Given this list of marker genes Deptor, Rtn2, Akr1b10, Rarres2, Bmp7, Cldn7, Adcy6, Npdc1, Klhl32, F5, Epcam, Larp6, Naglu, Dsg2, Hdc, Pigp, Gda, Eva1b, Tek, Nfe2l3 (nuclear factor, erythroid derived 2, like 3), Sesn3, Tmcc3, Sun2, Cpxm2, Stxbp6, Serpina1c, Ctso, Itgb5, Dnajc28, Ahnak2, Rras, Tsc22d1, Kcng1, Ddit4, Rgl3, Dmpk, Slc40a1, Chchd10, Pygb, Ncald, Arhgef26, Ren1, H2-T23, Tapbp, Cnp, Reck, Gstt2, Obp2a, Psmb8, Vps13b, Acsl4, Rab7b, Ifi44l, Olfml2a, Rab31, Natd1, Cyb5r3, Tbc1d4, Plin3, Ptk2b, Uap1l1, Chd3, Wipi1, Fuca1, Slc39a4, Mettl26, Sfrp4, Pdxk, Kcnj8, Tmtc2, Ptprr, Uba7, Hdac5, Klhl24, Apod, Gbp2, Notch3, Klra7, Gabrp, Oasl2, Mkrn1, Padi4 (NCBI Gene Id 18602), Rev3l, Ntn4, Cyp27a1, Selenom (NCBI Gene Id 216508), Tmem26, Plekhs1, Hvcn1, Mal2, Scn7a, Pdcd4, Tcf21, Lrp1, Trpm4, Rai2, Ip6k1, Renbp, Inava, Greb1, Arhgap6, Atp1b1, C1ra, Pnma8b, Nudt7, Abca1, Gbp2b, Hexa, Tef, Ampd3, Gdpd1, Tcim (transcriptional and immune response regulator), Ccdc80, Atp8a1, Wfdc17, Pnrc1, Kdm7a, Inhbb, Lipg, Mfge8, Trps1, Itgb8, Hsd17b11, Rgs3, Maf1, Mamdc2, Maf, Dtx3l, Cryz, Naa80, Ces2b, Esrp1, Eps8, Kank2, Apobec3, Vat1, Rad51b, Fam124a, Rbpms, Pkn1, Vwa5a, Vwf, Ern1, Slc7a2, Smad1, Plat, Extl3 (exostosin-like glycosyltransferase 3), Zfyve26, Mfap4, Rcsd1, Lcn2, Ggt5, Adamtsl1, Csrnp3, Mgp, Ppp1r9a, Stard9, Slc10a6, H2-Q6, Amhr2, Tspan8, Plpp6, Bckdha, Itgb4, Pgghg, Meis2, Mab21l3, Ugt1a2, Serpinb1a, Rbm24, Nnat, Mmrn2, Sdc4, Cpe, Pcp4, Dcxr, Asb2, Rnf130, Wdr45, Ip6k2, Mapkapk3 (NCBI Gene Id 235596), Mindy4, Cnppd1, Akr1c14, Cilp, Fbxo32, Plet1, Cdh1, Tbc1d17, Trpv6, Dchs1, Calb1, Abhd14b (abhydrolase domain containing 14b), Rhobtb1, Bmf, Foxp1, Pamr1, Mlph, Tspan1, Ssc5d, Rnase4, Hyi, Ntrk2, Zfas1, Tmem140, Mcee, Foxl2, Slc25a23, Aldh6a1, Ccdc136, Ptger3, Jun, Zfp608, Atp2b2, Cryzl2, Car2, Pycard, S100a1, Slc15a2, Tap2, Jak2, Satb1, Aoc3, Sh3bgr, Tmem35b, Resf1, Vldlr, Mfap2, Alox15, Cbr2, Gabarapl1, Spock2, Kdf1, Lad1, Fnbp1, Lmo2, Arf5, Fzd6, Itm2a, Atosa, Ppp1r12b, Acad8, Thra, Dbp, Traf5, Pnpla7, Ddit4l, 4933439C10Rik, Itgb3, Hspa12b, Capn5, Foxo3, Mettl27, Rsph3b, Cndp2, Reps2, Frmd4b, Alcam, Krt18, Pbxip1, Hacd4, Bphl, Serping1, Spint2, Calml4, Agrn, Msrb3, Spon1, Ccdc198, Plaat3, 2410006H16Rik, Adhfe1, Phactr2, Rims1, Trim45, Dio2, Ociad2, Ctsd, Krt19, Scarb2, Grina, Sftpd, Mturn (maturin, neural progenitor differentiation regulator homolog (Xenopus)), Ccdc28b, Tnxb, Creb5, Itpr2, Cd82, Dapk1, Rasd1, Vav3, Tnfsf12, Hoxd3os1, Atp1a2, Chodl, Ifitm1, Mme, Efhd2, Tmprss2 (transmembrane protease, serine 2), Gbp3, Smarca2, Col7a1, Cgnl1, Col18a1, Cyfip2, Hbp1, Bmp1, Pgm5, Ezr, Nfia, Cldn3, Ddrgk1, Abcb1a, Fbxl20, Plscr4, Clip3, Msx1, Scarb1, Cyp4v3, Cdc37l1, Nenf, Lepr, Hoxb6, Colec11, Lrp10, Krt88, Chkb, Npnt, Sncaip, Slc2a8, Ramp3, Nrtn, Ctdsp2, Sorcs2, Ar, Setd7, Pigr, Tmem45b, Sult1a1, Ptprd, Prxl2a, Urah, Radil, Numa1, Gpx2, Bche, Acaa1a, Antkmt, Tmem86a, Elapor1, Grb7, H2-K1, Ank3, Scmh1, Tmem176a, Jam2, Adgrg6, ENSMUSG00000143161, Ascc1, Ago1, Tmem213, Ilvbl, Gaa (glucosidase, alpha, acid), P2rx4, Ldhb, P2rx7, Ltbp1, Cpxm1, Coq8a, Ccng2, Eeig2, Spp1, Foxo1, Blvrb, Angptl7, Jmy, Inafm1, Irf6, Rab20, Zbtb16, Zfp36l1, Pdk2, Ngfr, Atp1b2, Tlcd5, Pxylp1, Akr1b7, Col6a1, Ramp1, Cxcl17, Cpz, Timp2, Fgl2, Slc26a7, Stmnd1 (NCBI Gene Id 380842), Slc24a3, Ckmt1, Hoxb5os, Grcc10, Sat1, Slc39a8 (solute carrier family 39 (metal ion transporter), member 8), Serinc3, Kctd14, Pam, Tnfsf13, Cul7, Clu, Rnf128, Hk1, Fxyd1, Zfp395, Rere, Trp53inp1, Ppp1r14b, Snai2, Cirbp, Crebrf, Pld1, Hdac11, Efemp1, Gbp7, Apoe, Rfxank, Fam20c, Prom1, Pde5a, Use1, Naaa, Gcnt1, Snx21, Ctxn1, Bmyc, Efs, Tmem176b, Ddah2, Itm2b, Sgms2, Higd1b, Lrig1, Rnd2, Gucy1a1, Itm2c, Nrep, Prss23, Lipe (NCBI Gene Id 71060), Armc10, Tmc4, Gsdmd, Fndc5, Ebp, Irf2, Rabgap1l (NCBI Gene Id 98656), Ifih1, Enpp3, Adra2a, Car12, Gstm1, Abca9, Fyco1, Msrb2, Bcat1, Abhd4, Inpp4b, 6330403K07Rik, Irgm2, AU021092, Coro1a, Lyz2, Sema4a, Adcy4, H2-Q5, Hpgd, Htra1, Aox1, Cxcl12, Pik3ip1, Ddr1, 2200002D01Rik, Slc31a2, Ehf, Bace2, Csad, Neat1, Gpm6b, Flcn, Tmprss4, Flot1, Afap1l2, Ltf, Anxa6, Cyp2d22, Arnt2, Smpdl3a, Nipal3, Prelp, Cd59a, Crip1, Igtp, Emp2, Sh3yl1, Firre, Cdh13, Slc16a2, Rasd2, Aqp1, Egflam (EGF-like, fibronectin type III and laminin G domains), Aspg, Ak3, Mecom, Sprr2f, Pdzk1ip1, Fam20a, Igfbp5, Apobec1, AW551984, Osr2, Ctsf, Rab6b, Sft2d2, Pth1r, Mxd4, Etfbkmt, Dlx5, Cpq, Scrn1, H2az2, Bcl2, Htra3, Fut9, Ptprb, C1galt1, Phldb1, Mmp11, Agtr1a, Phpt1, Ghr, Igsf3, Aebp1, Glb1, Gm32031 (predicted gene, 32031), Ltbp4, Ypel3, Fcgrt, Aamdc, Emb, Casp12, Cldn23, Rnasel, Rspo3, Irag1 (NCBI Gene Id 233729), Col5a1, Map1lc3b, Vsir, Serinc2, Ephx1, Cited4, Plek, Muc1, Kcnd2, Dpt, Faap20, Cep83os, Rbm39, Zfand3, Ift46, Synpo2, Nmi, Col6a4, Otub2, Slc7a7, Krt8, Gm5817, Tmt1a, Appl2, Cd14, Pdlim2, Psrc1, Sult1d1, Npr2, Ckb, Gng2, Dazap2, Nbl1, Fblim1, Tfcp2l1, Aqp8, Cbx6, Lix1l, Map1lc3a, Nr1d2, Lrrc17, Prlr, Qprt (quinolinate phosphoribosyltransferase), Jag1, Gstt1, Snrk, Cldn34c1, 4931406C07Rik, Pard3b, Btg1, Peli2, Ier3, P2ry14 (purinergic receptor P2Y, G-protein coupled, 14, NCBI Gene Id 320463), Fzd7, Grn, Slc48a1, Chdh, Matn2, Gsto1, Dap, Il17rd, Pdk4, Septin4, Rnf150, Bex1, Cln3, Cplx2, Slc6a9, Enpp2, Bcl2l11, Smim29, Kif16b, Tnnt1, Pdgfa, Zfp867, Anpep, Manba, Fuom, Sesn1, Clca1, Zbtb4, Plxnb2 (NCBI Gene Id 73840), Lama2, Smarca1, Mmp23, Acacb, Usp18 (NCBI Gene Id 68782), Vtn, Nkd2, Irs1, Pcbd1, Pik3r1, Cast, Entrep1, Prkar1b, Fbln5, Cryl1, Angptl2, Igf2r, Prkd3, Adh1, Rgma, Kctd1 (potassium channel tetramerisation domain containing 1), Naga, Tie1, Tmem30b, Plscr1 (phospholipid scramblase 1), Naprt, Padi1, Pck2, Cp, Thbd, Gpr146, Tamalin, Msrb1, Tmem200c, Txnip, Haghl, Ypel2, Msc, Cebpd, Ccl11, Pdpn, Fgd4, Plpp2, Clec14a, Rab25, Mycn, Serpina1b, H2-T10, Wfdc2, Glb1l2, Aldh1a2, Tmem132c, Dcaf8, Rnf167, Unc93b1, D430019H16Rik, Aox3, Casp1, Krt7, Prxl2c, Rab13, Cyp39a1, Lrpap1, Tctn1, Ctsh, Ddb2, Rusc1, Creg1, Bspry, Il18, Per3, Dpyd, Slc17a5, Rragd, Igfbp6, Oxld1, Ctsb, Ndrg2, C1s1, Klf9, Paox, Foxl2os, Ctsa, Lpl, Ednra, Mpzl2, Rftn2, Col4a4, Stom, Cacnb3, Grb14, Pink1, Kcnk1, Arl4c, Dsp, H2-D1, Dtx4, Oplah, Sv2b, Lrrk1 (leucine-rich repeat kinase 1), 4930523C07Rik, Degs2, Mal, Cry2, Col6a2, Aard, H1f10, Galnt15, Gm14226, Pik3r3, Fmo2, Tgfb1i1 (transforming growth factor beta 1 induced transcript 1), Fxyd6, Rab29, Calcoco1, Slc35g1, Axin2, Kcnab1, Slco2b1, Ppp1r14a, Entpd1, Slc5a8, Dgka, H1f2, Rpl22, Selenow, Tcp11l2, F3, Ripor2, H6pd, H2ac25, Pltp, Man1a, Wls, Plod1, Fam107a (NCBI Gene Id 268709), Fads2b, Spsb4, Dpp4, Zfp467, Sgpp2, Oxtr, Crispld1, Tril, Tjp2 (tight junction protein 2), Cldn10, Crispld2, Qpct, Ppm1e, Celf2, Dhrs7, Zfp521 (NCBI Gene Id 353027), Samd14, Rtkn, Sash1, Clstn1, Prss8, Krt15, Thbs3, St14, Mxra8, Phf11a, Mylip, Ttc28, H1f0, Glmp, Wfs1 (NCBI Gene Id 22393), Tcn2, Nupr1, here is a description of the gene set: from publication Lee KY, Jeong JW, Wang J, Ma L, Martin JF, Tsai SY, Lydon JP, DeMayo FJ (PMID 17515606) Mouse Gene Set: LEE_BMP2_TARGETS_UP Genes up-regulated in uterus upon knockout of BMP2. studied in species Mus musculus The process of implantation, necessary for all viviparous birth, consists of tightly regulated events, including apposition of the blastocyst, attachment to the uterine lumen, and differentiation of the uterine stroma. In rodents and primates the uterine stroma undergoes a process called decidualization. Decidualization, the process by which the uterine endometrial stroma proliferates and differentiates into large epithelioid decidual cells, is critical to the establishment of fetal-maternal communication and the progression of implantation. The role of bone morphogenetic protein 2 (Bmp2) in regulating the transformation of the uterine stroma during embryo implantation in the mouse was investigated by the conditional ablation of Bmp2 in the uterus using the (PR-cre) mouse. Bmp2 gene ablation was confirmed by real-time PCR analysis in the PR-cre; Bmp2fl/fl (termed Bmp2d/d) uterus. While littermate controls average 0.9 litter of 6.2+/-0.7 pups per month, Bmp2d/d females are completely infertile. Analysis of the infertility indicates that whereas embryo attachment is normal in the Bmp2d/d as in control mice, the uterine stroma is incapable of undergoing the decidual reaction to support further embryonic development. Recombinant human BMP2 can partially rescue the decidual response, suggesting that the observed phenotypes are not due to a developmental consequence of Bmp2 ablation. Microarray analysis demonstrates that ablation of Bmp2 leads to specific gene changes, including disruption of the Wnt signaling pathway, Progesterone receptor (PR) signaling, and the induction of prostaglandin synthase 2 (Ptgs2). Taken together, these data demonstrate that Bmp2 is a critical regulator of gene expression and function in the murine uterus.